The following is a description of a gene set: Human Gene Set: GOMF_ATP_DEPENDENT_DNA_DAMAGE_SENSOR_ACTIVITY A molecule that recognises toxic DNA structures, and initiates a signaling response, driven by ATP hydrolysis. studied in species Homo sapiens, and this is the list of marker genes: PMS2P1, PMS2P6, RAD51, MLH1, MLH3, PMS2P3, RAD51D, MSH6, XRCC3, XRCC2, MSH4, MSH2, DMC1, PMS2P5, RAD51C, PMS1, PMS2, MSH3, ERCC6, MSH5, RAD51B